Given this list of marker genes NRXN1, NUS1, USP9X, CIB2, RANBP2, WNK3, CLEC2D, PARP12, GABRA6, COL11A1, RBM47, ADAM12, ENPP1, HEATR6, CRLF1, DNAJC12, PPP1R3C, CD79B, ZNF385B, GALNT12, BTG1, XIST, RUNX3, PROKR1, TCN2, IRGM, OMD, here is a description of the gene set: The reciprocal chromosomal translocation t(4;11) is correlated with infant, childhood, adult and therapy-related high-risk acute leukemia. Here, we investigated the biological effects of MLL.AF4, AF4.MLL or the combination of both reciprocal fusion proteins in a conditional in vitro cell culture model system. Several parameters like cell growth, cell cycling capacity, apoptotic behavior and growth transformation were investigated under physiological and stress conditions. Co-transfected cells displayed the highest resistance against apoptotic triggers, cell cycling capacity and loss-of-contact inhibition. These analyses were complemented by gene expression profiling experiments and specific gene signatures were established for each of the three cell lines. Interestingly, co-transfected cells strongly upregulate the homeobox gene Nanog. In combination with Oct4, the Nanog homeoprotein is steering maintenance of pluripotency and self-renewal in embryonic stem cells. Transcription of Nanog and other stem cell factors, like Oct4 and Bmi1, was verified in biopsy material of t(4;11) patient cells which express both reciprocal t(4;11) fusion genes. In conclusion, the presence of both reciprocal MLL fusion proteins confers biological properties known from t(4;11) leukemia, suggesting that each of the two fusion proteins contribute specific properties and, in combination, also synergistic effects to the leukemic phenotype. from publication Gaussmann A, Wenger T, Eberle I, Bursen A, Bracharz S, Herr I, Dingermann T, Marschalek R (PMID 17130830) species: Mus musculus Human Gene Set: GAUSSMANN_MLL_AF4_FUSION_TARGETS_B_UP Up-regulated genes from the set B (Fig. 5a): specific signature shared by cells expressing either AF4-MLL or MLL-AF4 fusion proteins.